Given this list of marker genes MIR1-1, ARID2, TGFBR3, FGF2, PDGFRB, LRP2, SEC24B (NCBI Gene Id 10427), TBX1, SPRED1, HEY2, HAND2, TBX5, VEGFA (NCBI Gene Id 7422), SGCD, NRP1, TGFBR1, NOTCH1, here is a description of the gene set: Human Gene Set: GOBP_CORONARY_VASCULATURE_MORPHOGENESIS studied in species Homo sapiens The process in which the anatomical structures of blood vessels of the heart are generated and organized. The blood vessel is the vasculature carrying blood.